The following is a description of a gene set: Human Gene Set: DAVICIONI_MOLECULAR_ARMS_VS_ERMS_UP studied in species Homo sapiens Alveolar rhabdomyosarcomas (ARMS) are aggressive soft-tissue sarcomas affecting children and young adults. Most ARMS tumors express the PAX3-FKHR or PAX7-FKHR (PAX-FKHR) fusion genes resulting from the t(2;13) or t(1;13) chromosomal translocations, respectively. However, up to 25% of ARMS tumors are fusion negative, making it unclear whether ARMS represent a single disease or multiple clinical and biological entities with a common phenotype. To test to what extent PAX-FKHR determine class and behavior of ARMS, we used oligonucleotide microarray expression profiling on 139 primary rhabdomyosarcoma tumors and an in vitro model. We found that ARMS tumors expressing either PAX-FKHR gene share a common expression profile distinct from fusion-negative ARMS and from the other rhabdomyosarcoma variants. We also observed that PAX-FKHR expression above a minimum level is necessary for the detection of this expression profile. Using an ectopic PAX3-FKHR and PAX7-FKHR expression model, we identified an expression signature regulated by PAX-FKHR that is specific to PAX-FKHR-positive ARMS tumors. Data mining for functional annotations of signature genes suggested a role for PAX-FKHR in regulating ARMS proliferation and differentiation. Cox regression modeling identified a subset of genes within the PAX-FKHR expression signature that segregated ARMS patients into three risk groups with 5-year overall survival estimates of 7%, 48%, and 93%. These prognostic classes were independent of conventional clinical risk factors. Our results show that PAX-FKHR dictate a specific expression signature that helps define the molecular phenotype of PAX-FKHR-positive ARMS tumors and, because it is linked with disease outcome in ARMS patients, determine tumor behavior. from publication Davicioni E, Finckenstein FG, Shahbazian V, Buckley JD, Triche TJ, Anderson MJ (PMID 16849537) Genes up-regulated in mARMS (molecular ARMS) compared to the mERMS (molecular ERMS) class of rhabdomyosarcoma tumors., and this is the list of marker genes: ARHGEF4, WWOX (WW domain containing oxidoreductase), TFF3, TSPAN3, SPINT2, FRMPD1, DDR1, KDM4C, ACOT9, KIF1B, SYN2, RASSF4, SLC27A6, RAP1GAP2, GMIP, SH3GLB1, AKTIP, ADRA2C, HDAC5, CHD7, CRMP1, ISCA1, CYB561, PITRM1, MED13L, CNR1, CLCN3, GREM1 (NCBI Gene Id 7947), TFAP2A, NR0B1, RAPGEF4, GADD45A, NNT (nicotinamide nucleotide transhydrogenase), PRKX, CRIP2, ZNF248, DISC1, SAMD4A (NCBI Gene Id 26078), CSRNP2, SUN2, NRN1, JARID2, KLF7, JAKMIP2, ARHGAP26, TMEM120B, CAMSAP1, SLC38A1, PRMT2, CELA2B, DAPK1, GYPC, OAT, MMUT, ARHGAP6, TMEM131L, SMARCA5, GGNBP2, PLPP1, BCL2L13, LMO4, SOS2, CCP110, MSRB1, PCMT1, MYMX, BMERB1, FRY, QDPR, PEBP1, TEFM, BLCAP, OLFML2B, GOT2, ABCG1, OLIG2, TRIM37, SCAMP1, DLGAP2 (DLG associated protein 2), VIPR2, MYOD1, HCCS, MTMR4, ARHGEF2, SLC30A9, RNF38, NOTCH1, AGTPBP1, RRAGA, IFT81, CDS2, MET, CHST8, GNB1, ASS1 (argininosuccinate synthase 1), RNF11, EFHD2, S1PR1, TMEM47, IQCG, ASRGL1, SYNE2, CEP104, TLK2, DLK2, ANKS1A, CAAP1, SPIN2A, ZNF91, ERP44, EDN3, KCNN3, TXNIP, ADRA2A, BCL11A, HMGN4, RRAGD, ZNF43, DTWD1, PODXL, ENO3, CHRNB3, PSME1, WARS1, GCA, EMC9, MYCN, AP5M1, BRINP1, RNF111, DIO2, TRPV1, C14orf132, CDK2AP1, PRKAR2B, PGBD5, TEX2, ZBTB18, NRCAM, POR, TOX3, EYA2, ASCC3, ECHS1, SPATS2L, NUDT11, MEOX1, PIPOX, KATNIP, PAX2, PDZRN3, FRYL, PIMREG, NET1, MXRA7, MLH3, NF1, MYOG, TSTD2, DHFR, COQ9, SYNCRIP, WASHC3, CPD, SMPDL3A, LRRFIP2, TMEM260, RAB28 (NCBI Gene Id 9364), MARCHF3 (NCBI Gene Id 153277), COL18A1, MYLIP, CLIP1, TRIM36, PSEN2, ARL3, FAN1, DET1, PCSK6, TBCD, SESN1, ERI2, COBL, DOCK9, LIPG, KCND3, TBCA, ZCCHC14, PAX5, ARRB1, GABPB1-IT1, MNAT1, ACYP1, PEG3, HSF2 (heat shock transcription factor 2), PBK, TFAP2B, DAG1, CDC42EP3, TTC19, TBC1D9, TOPORS, CDH3, DST, POLG2, DZIP3, ARHGAP25 (Rho GTPase activating protein 25), RIPOR2, PTBP2, TOM1L1, TEX14, ELOVL2, TAGLN3, RYR3, TULP4, ACO1, NMRK1, HPRT1, PTPRD, FGFR2, CLCN5, BBIP1, CDC14B, PLPPR1, SLC24A3, IL4R, ADAM10, CAPN6, CUL3, NRTN, DCX, ADK, CCNH (cyclin H), SATB2, RBPJ, NCOA1, SGPL1, DNASE1L1, BRD3, NPEPPS, DIXDC1, COG2, TSC22D2, EIF1AX, FGFR4, MEGF9, MORC4, ARL17A, RBM8A, WSCD1, COX7A1, ROGDI, SHOC2, NHLH1 (nescient helix-loop-helix 1), POPDC3, MYO18A, FLVCR2 (FLVCR choline and putative heme transporter 2), PIGN, SLC9A6, ARPP19, NTRK3, FOXO1, AKT3, LINC00588, ANKRD17, MAPK6, CTBP2, PARP1, TSPYL4, POU4F1, CEP68, SNAI1, BMP5, B3GAT1, RANGRF, STC2, MINDY2, PPM1H, MYO1E, DIPK1A, MAMLD1, PPP3CA, MICAL1, CD47, MARCHF6, RNF5, SRSF4, MAGI2, DNMBP, ACOT7, RNGTT, PKP4, NLGN4X, MYB, PCNT, TNFAIP1, GADD45G, NKAIN1, USP12, KANK1, HERC2, NPC1, GNE, UBR2, HSBP1, FTO, ELMO1, MDC1, AMZ2, CLASP2, PAIP1, ZNF330, SEL1L3, FBXL5, PSMB2, LPAR2, RGS17, MREG, GOSR1, CDYL, SLC46A3, ALK, FBXO9, SEMA5A, THUMPD1, ANK2, PRRC2B, ENDOG, ASTN2, SGMS1, ABAT, NELL1, PAFAH1B1, MAN1C1, CDK14, STX7, MAP1LC3B, FOXF1, PIAS1, LSP1P5, PTPRF